Given this list of marker genes ZIC3, CRIPTO, FOXD3, SOX2, STAT3 (NCBI Gene Id 6774), FGF2, NANOG, EPHA1, NR6A1, POU5F1, SALL4, SALL1, DPPA4, here is a description of the gene set: POU5F1 (OCT4), SOX2, and NANOG bind elements in the promoters of target genes. The target genes of each transcription factor overlap extensively: POU5F1, SOX2, and NANOG co-occupy at least genes. About half of POU5F1 targets also bind SOX2 and about 90% of these also bind NANOG. Upon binding the transcription factors activate expression of one subset of target genes and repress another subset. The targets listed in this module are those that have been described as composing activated genes in the core transcriptional network of pluripotent stem cells. Inferences from mouse to human have been made with caution because of significant differences between the two species. Reactome Pathway: POU5F1 (OCT4), SOX2, NANOG activate genes related to proliferation part of: Transcriptional regulation of pluripotent stem cells studied in species Homo sapiens